The following is a description of a gene set: Human Gene Set: GOMF_STRUCTURAL_CONSTITUENT_OF_POSTSYNAPTIC_ACTIN_CYTOSKELETON studied in species Homo sapiens The action of a molecule that contributes to the structural integrity of a postsynaptic actin cytoskeleton., and this is the list of marker genes: ACTG1, POTEF, ACTB, POTEKP, ACTBL2, POTEE, POTEJ, DBNL (drebrin like), ACTL8, POTEI, ACTN2